The following is a description of a gene set: Reactome Pathway: Synthesis of pyrophosphates in the cytosol part of: Inositol phosphate metabolism Inositol phosphates such as IP4, IP5 and IP6 are converted to an even wider variety of IPs including the di- and triphospho inositol phosphates, also known as pyrophosphates (Irvine & Schell 2001, Alcazar-Romain & Wente 2008, York 2006, Monserrate and York 2010, Ho et al. 2002, Saiardi et al. 2001, Draskovic et al. 2008, Choi et al. 2007, Caffrey et al. 2000, Leslie et al. 2002). species: Homo sapiens, and this is the list of marker genes: NUDT11, ITPK1, NUDT4, IP6K1, NUDT3, PPIP5K1, IPPK, PPIP5K2, IP6K3, NUDT10